Given this list of marker genes MAPK1, RPS6KA3, RPS6KA1, RPS6KA6 (ribosomal protein S6 kinase A6), MAPK3, PDPK1, RPS6KA2, here is a description of the gene set: RSK activation Human Gene Set: REACTOME_RSK_ACTIVATION species: Homo sapiens